Given this list of marker genes FGF2, MIR320E, NR2E1, PRRX1, SHOX2, MIR93, FERMT2, MIR320C2, RUNX2, MIR320D2, HOXA3, HMX2, FGF10, FGFR1, KDM1A, NANOG, CITED1, MIR320D1, FGF4, TGFBR1, SOX9, FGF9, TP63, CTNNB1, ATXN1L, MIR320B2, N4BP2L2, CCNE1, MIR320B1, SIRT6 (sirtuin 6), KITLG, PBX1, TBX3, OSR2, GJA1, VEGFC, TERT, WNT10B, HMGA2, EPCAM (epithelial cell adhesion molecule), MIR320A, MIR320C1, FGF8, SOX11, HNRNPU, KDR, WNT5A, LTBP3, TGFB1, ELL3, PDCD2, THPO, KAT7, PTPRC, WNT1, here is a description of the gene set: studied in species Homo sapiens Human Gene Set: GOBP_POSITIVE_REGULATION_OF_STEM_CELL_PROLIFERATION Any process that activates or increases the frequency, rate or extent of stem cell proliferation.